The following is a description of a gene set: Genes containing one or more binding sites for (HES2) in their promoter regions (TSS -1000,+100 bp) as identified by GTRD version 20.06 ChIP-seq harmonization. from publication Yevshin I, Sharipov R, Kolmykov S, Kondrakhin Y, Kolpakov F (PMID 30445619) Human Gene Set: HES2_TARGET_GENES studied in species Homo sapiens, and this is the list of marker genes: ADD3, GNAL, SHISAL2B, NACA4P, NRP2, ENSG00000249631, KIFC3, BTF3L4, NEMP1, LINC02214, RPL24, IL1R1, GFPT2, AMBRA1, RNU6-466P, MALAT1, TPRA1, LINC01093, ENSG00000267174, WWTR1, ZC3H12C (zinc finger CCCH-type containing 12C), SLC2A9-AS1, OSBPL1A, SLC7A11, CUEDC1, HISLA, VLDLR-AS1, EPHA2-AS1, MMS19 (NCBI Gene Id 64210), DUSP1, GDI1, PDK1, H2BC21, TNKS1BP1, MIR5194, LINC01719, NRXN2, TUT1, TBC1D16, RN7SKP192, LINC00511, TGFBR2, TM2D2, ABHD16A, C8orf74, MIX23, RNF145, SIAH1, CSF2RA, GPD1L, PDXK, P4HA3, PRCP, CHI3L2, RPL31P43, HMGN1P33 (NCBI Gene Id 100874446), CCL20, MED20, DDIT3, DRAP1, SSR1P2, MED28, CD200R1L-AS1, MTHFD2L, LINC00680, C4orf33, WDPCP, FNDC3A, LDLRAD4, MASP1 (NCBI Gene Id 5648), SAA1, CHP1, ENSG00000226087, ABT1, SLC33A1, FAM107B, XPC-AS1, ASB9, UQCC6, HOXC-AS2, MED28-DT, GPR182, ZSWIM2, PSME2P3, LINC00887 (long intergenic non-protein coding RNA 887), LTBR, RPL39P5, ENSG00000275465, ALG10 (NCBI Gene Id 84920), CXCL8 (NCBI Gene Id 3576), DTWD1, NEDD4, MIR4435-2, LINC01767, MFSD4B, CTR9, PRR13P5, BCL10, ENSG00000267882, FGFR4, ATP9B, SHC4, LINC02843, LINC02454, AIG1, LINC01619, MTCP1, PPP1R15B, TMEM143, VAV3, MIR100HG, TRAF2, EIF4A1, EML2, FKBP9, NECTIN4-AS1, ATG10, PCBP2, SH3TC1, ENSG00000227619, GRIA3 (glutamate ionotropic receptor AMPA type subunit 3), C1QTNF6, BBC3, NDRG1, CAMK2G, EFCAB2, SPRED2, CASK, ABHD12, RPL36AP19, MIR587, MEIS1, GASAL1, HRH1, S100A10, CEP112, KCNK1, MRPS35-DT, IRF2BP1, FGD4, AURKA, SMIM20, SCG5, ANKRD40 (NCBI Gene Id 91369), ENKUR, EDN3, NKILA, DHRS9, HSPA9, FOSL2, CCDC159, BRD4, LINC-PINT, MTARC1 (NCBI Gene Id 64757), RAB5IF, NRAD1, CCNG2, PPARG, SLC38A1, VWA8 (NCBI Gene Id 23078), ISL2, MSL2, LINC02474, APOLD1, ZNHIT1P1, PRDM15, RARB, TSPAN19, BMF, ADGRF4, HRG-AS1, MRPL46, RNA5SP282, TM4SF1-AS1, TPM4, PPP4R1L, IRF2-DT, ZNF641, AOX3P, CLDN7, FPGS, ENSG00000249236, PTPRM, ZNF420, RNU5A-1, ADAM9, CHD2, LINC00706, PLAC1, ZNF547, RNF212, CHD1, SCNN1A, PLD1, IL1RAP, CYP3A43, MDH1, LINC02320, LINC02923, ENSG00000267015, DDIT4, SNORA48, DIO2, EIF4E, RPL35AP17, TRIM29, C2orf76 (NCBI Gene Id 130355), ENAH, EIF5A2, CAPN8, LBP, USP3, NFIA, RPS18P1, TIGD2, GSN, CCND3, BNC2, TPD52L2, NDUFA12, ENSG00000283573 (novel transcript), RAB3D, RBMS3-AS3, GDPD1, LINC02289, AGK, HDAC11-AS1, APBA3, ADRM1, RRBP1, LINC02895, PDK4-AS1, TM4SF1, ANXA2R, PGAM1, PTGFR, DYNLL1P6, LMO7, HNF4A-AS1, WSB2, NGLY1, HM13-AS1, ABCA10 (ATP binding cassette subfamily A member 10), STAT6, STAU2-AS1, POR, RPL4P6, EHF, P4HB, ALG3, COX6CP5, RDX, GALNT9, PLCE1, KIAA2012, ENSG00000225676, LUCAT1, CLIP1, PDK4, OLAH, PNRC1, MARCHF7, C3, SMARCA2, PUDPP1, PTGS2, PNRC1-DT, HCG20, LINC01094, JPX, ZNF280A, IFNL3, SYNCRIP, ZNF619P1, JDP2-AS1, TFRC, ACAP3, KIF17 (kinesin family member 17), LINC02015, MLIP, RCAN1, GAS7, CLDN6, NEAT1, SLC2A4RG, KLF7, NSFL1C, HBP1, MRPS31 (NCBI Gene Id 112759), SLC3A2, CRYBG1, PLOD2, TCF7L2, TFEB, CCDC57, BMP1, FADS1, RNU6-1220P, LINC01134, CHN2, ARHGAP26, EPHB4, RHEB, JPH2, KRT7-AS, CUL3, RPL6, SLC23A1, ZNF286A, ALDH3B1, ENSG00000270571, LCE3D, SNORC, STAT1, E2F2, CELSR1, C1orf21, RNU4-88P, BRF2, TEAD1, GTF3C3, YAP1, PNP, LINC02104, LINC03033, LONRF3, UGT2B10, HNRNPF, AP1G1, PRAME, MIR5696, BNC2-AS1, TMBIM1, DCDC2, CXADR, TDP2, ACOT13, ENSG00000187185, RBBP5 (NCBI Gene Id 5929, RB binding protein 5, histone lysine methyltransferase complex subunit), RPSAP75, TM9SF5P, ADAP1, MANCR, LAMP1, ZBTB7A, GNL3L, PIGO, PNPLA1, ENSG00000227496, SAXO5, INTS5, PDCD6, DENND3, TANK-AS1, CLN6, EP400P1 (EP400 pseudogene 1), CXCL2, LINC02185, FADS3, ITPRIPL2, MMP19, NPIPB8, LINC01730, LINC00160, MSANTD3, SMAD1, SLC44A1, SET, FAM219B, MYOSLID, FERMT2, TLR5, SSBP2, BAZ2B-AS1 (NCBI Gene Id 649559), RFESD (NCBI Gene Id 317671), ATXN10, TPK1, ZNF529 (zinc finger protein 529), FGA, KCNE1, TOMM5, COL7A1, ATXN7L1, MAPK3, PIK3C3, ZNF276, RBM39, EFNA1, PIGU, STAU1, CFAP144P1, KRT8, PARP8, ADHFE1, BUD31, CLASP1, MRO, GPAT3, CLVS1, FMN1, RNA5SP334, CRIPTOP2, LINC01485, HMG20A, COLEC11, PDLIM7, SCUBE2, PIGT (phosphatidylinositol glycan anchor biosynthesis class T), FSIP1, KAT6A, MBP, DNMT3B, LINC01910, DLG5, LRIG3, SLC25A5P7, IGLV3-22, PIK3C2B, CDCA2, H4C10P, SUPT5H, B4GAT1, NFIB, TRPC4AP, CUL2, DEPDC4, MFSD4B-DT, THRA, S100P, PHACTR4, IQGAP2, GZF1, SYBU-AS1, HIVEP2, ETF1, INHBE, SPX, HTR1D, GCLC, ZNF217, CALCOCO2, ITGB1, PSMG3, NFIA-AS1, RBM45, LINC02615, VWC2L, LINC02098, YARS1, KLF13, CDHR17P, STRA6, OSTCP1, DTNA, OR10J6P, LINC02934, S100A12, HES4, UGT2A3P7, SLC7A6, DHRSX, MIR4530, LOLI1, GLTPD2, CHAC1, TFE3, PDE7B-AS1, GUSBP1, RNA5SP146, TMSB4X, RPL7P30, FBXL5, CD59, RPL39P40, KAT2B, TRAPPC5, CDKL3, HDAC11, SGK3, TRPM8, UST-AS2, LINC02888, DPH6, TRAPPC2B, TUBA1C, CALD1, FLJ42393, ENPP3 (ectonucleotide pyrophosphatase/phosphodiesterase 3), C4orf51, RGS20 (regulator of G protein signaling 20), IFNGR1, SMG8, ZNF594, SH2D5, CEACAM19, ACOT7, CYGB, ARFIP1, CNIH3, NFKBIA, SEPTIN2, KIAA0232, ANAPC5, SAMD4B, UBOX5, PRMT5-DT, RAB39B, CIPC, MRPS30-DT, MECP2, LRRFIP2, NAA50P2, RBP4, SRRM3, ANKRD1 (ankyrin repeat domain 1), NMI, ERI1, ZFP36L2, MIB1, ZNF354B, KDM4A, ISG20, LRRC27, ABLIM1, ASCC2, EHMT1 (euchromatic histone lysine methyltransferase 1), POLE4P1, LINC02275, BCO2 (beta-carotene oxygenase 2), KLHDC4, CFLAR-AS1, SMIM14-DT, HOXD11, DDIAS, HK1, LINC00111, AKR1C4, DLGAP1-AS2, LRRC77P, SSTR5-AS1, MNT, SGPP1, GLYATL1, ECHDC3, FAM13A, ABLIM2, ENSG00000239142, RNU6-411P, ENSG00000266313, RUVBL1, ARHGEF19, PER1, CAPS2, NR3C1, MARCHF5, RNU6-1013P, HAL, HAVCR1, NR4A1, TMEM205, FHAD1, MIR4289, ALDH1A2, PNPLA2, LINC01127, SEPTIN9, SMIM36, ZBTB38, ATP5MC2 (NCBI Gene Id 517), E4F1, SCLT1, PRKXP1, ENSG00000199566, SUMO2, AKNA, MIR4440, SLFN12, SLC38A2, TPRG1-AS1, GDF15, PARAL1, SLC2A14, FHL1P1, TET2 (tet methylcytosine dioxygenase 2), CLDN2, RERGL, B4GAT1-DT, TMED2, GNA15-DT, RNF149, NEDD4L, HERPUD2, LRBA (NCBI Gene Id 987), PITPNM2-AS1, ZFAND5, UTY, DPY19L1, TXNRD1 (NCBI Gene Id 7296), HDLBP, DDX27, NAB2, KATNBL1, NCR3LG1, CECR2, ELF1, MRPS23, NBL1, FRG1CP, RNU6-304P, MDP1, ZBTB44, MIR99AHG, SOCS3-DT, MCCC1, RPL7AP4, PLEKHM1 (NCBI Gene Id 9842), ZNF414, SRBD1, CISD1, XPO6, RNU6-117P, CDC7, PVT1, STX1A, NR1H3, NRP1, SPRY4-AS1 (SPRY4 antisense RNA 1), HMGA1P3, SBNO2, RPS6KB1, LINC02331, MTHFD1, GSDMC, EID1, HSPE1-MOB4, SRCIN1, GARS1, PRDM6, ATP11C, RPL26, AADACP1, CIDEC, MRPS5, C4orf46, ORC1, GALNT10, LLPHP3, SH3GL1, FAM227B, ELOVL6, MIOS-DT, EIF2AK3 (eukaryotic translation initiation factor 2 alpha kinase 3), C1orf174, VPS9D1, ZBTB20, ZNF580, ENSG00000229425, HMGCL, MCTP1, KDM3A, TMED10, NCOA7, LINC01151, RN7SL299P, CDK12, KLHL6-AS1, ADCY7, AVL9, ZNF581, HSPE1, SESN2, CCDC192, FAM83A, CAPS (calcyphosine, NCBI Gene Id 828), WDR7, MRPS15, CSTF1 (cleavage stimulation factor subunit 1), NFKBIZ, H4C4, ATP8B4, S100PBP, TMEM91, CS, ZFR, SLTM, MEST, XRCC5, RNA5SP441, RNU1-38P, VMP1, ALDH3A1, LINC02882, NDUFB11, MID1IP1, FBXL18, PUSL1, TBPL1, HSPD1, PMEPA1, TEX41, RN7SL570P, RNVU1-6, UBC, RNY3P12, TRMU, SPPL2A, ALKBH3-AS1, PRPF38A (pre-mRNA processing factor 38A), AJUBA, LINC01433, BEST1, ATAD1, MRPS35, DDC, PDE4D, ERCC4, RASSF9, ITGB3BP, NDUFS4, LINC01775, CLEC4G, USP43, MT2A, ABHD11, PDCD1LG2, FGF14, DENND2B, USP9X, SNORD65C, H2AZ1-DT, MT1F, ETNK2, RDH11, AGPS, ACOX2, DLGAP1, KLF2-DT, ECE2, MYH9, COQ5, LONRF1, RSU1, TRIB1, KLF5, PAM16, TNIP1 (NCBI Gene Id 10318), MAP2K3, ETV6, DHRS12, ARNT, PAXBP1, OAZ1, KNL1, ZNF14, NUF2, PTCH1, PPP1R3B-DT, CALHM5, CCDST, IFT122, IRAK3, IGF2R, THADA, MTMR12, ZNF391, SCMH1, UBXN7, CFAP418, NXN, EPS8, SLC38A4-AS1, FGGY-DT, HGD, MLPH (melanophilin), PDLIM5, PDHA1P1, ENSG00000232995, LINC02198, LURAP1L-AS1, RAB37, EZR-AS1, LINC00598, EVL, TGFBI, RNU5E-6P, PNN, LINC01366, ENO1, SLC9A1, PECR (NCBI Gene Id 55825), IGFLR1, ADAM28, DAAM1, OR10AC1 (NCBI Gene Id 79304), GTF2F2, TCEANC, GREB1, PDCD4-AS1, PLEKHG2, UGT2B28, PRKG2-AS1, ZNF263, MKNK2, ARHGAP24, S100A8, CAV1, ASNSD1, ENSG00000273077, RPSAP65, ZMAT1, FGL1, CUX1, UGT1A7, CASC15, LINC02569, RHCG, DLEU2, DLGAP1-AS1, MISP3, EYS, CLCF1 (NCBI Gene Id 23529), GABRE, TSFM (Ts translation elongation factor, mitochondrial), LINC02410, PTENP1-AS, MBD4, CHEK2, DDB2, TEX12, METTL15 (methyltransferase 15, mitochondrial 12S rRNA N4-cytidine), ALG13 (ALG13 UDP-N-acetylglucosaminyltransferase subunit), MROH1 (NCBI Gene Id 84500), PIWIL2, CYP4B1, RDH12, SNORD118, MIR3611, SHANK2, CFB (NCBI Gene Id 629), KLRK1, GARS1-DT, C1orf226, MIR4799, PER2, OSMR, CCDC88B, LINC00431, PDAP1, TPT1-AS1, ENSG00000212273, RNU4-71P, KRT7, ALOX5AP, FLNB, LINC02026, MBNL1, LINC01275, CCDC9B, ROS1, OGT, TRPM7, LINC00466, RPS7, STAT4, CDK5RAP2, S100A9, NRG1, SKIL, PCID2, SLC22A4, AURKAIP1, ANXA11, CHAF1A, LINC01126, PIGO-AS1, RMDN3, VIM, HSD11B1, MIR3649, EXOC3L4, NME1, TSBP1-AS1 (TSBP1 and BTNL2 antisense RNA 1), ENO3, ABCF2 (ATP binding cassette subfamily F member 2), TNS1 (NCBI Gene Id 7145), RNU1-39P, STAT3, HMGN1P18 (high mobility group nucleosome binding domain 1 pseudogene 18), TXNDC11, HIVEP1, ITPRIP, ABCC3, FUT5, P2RY8 (P2Y receptor family member 8), LINC02831, CYP4A11, LCN2, AOPEP, CCDC171 (NCBI Gene Id 203238), UGT2A2, MAP3K8, ZDHHC3, TGFBR1, CDKL4, EHD1, DAW1, PSMA1, HOOK2, LINC00824, CSAD (cysteine sulfinic acid decarboxylase), RPL34, HECW2-AS1, RNA5SP44, TTI2, OSMR-DT, EFNA5, WASF1, ZNF221, CLK4, ADAR, LINC02209, CSGALNACT1, RUSC2, WIZ, SCN8A, SNX8, SEC62, ISG15, BTBD19, BOD1L1, LINC02352, ABCG1, OR7L1P, CFD, FBN3, JDP2, ZNF200, LINC00112, MIR4276, SMARCD2 (SWI/SNF related, matrix associated, actin dependent regulator of chromatin, subfamily d, member 2), ABCA5, FADS2B, PTP4A1, FTL (NCBI Gene Id 93315), RPL34P18, NIBAN2, GCC2, PRAF2, ERGIC1, SERPINB9P1, DNASE1L3, BMERB1, LMX1B, LINC01909, ENSG00000225656, ANKRD11, IER3-AS1, ENSG00000282849, ITGB1-DT, EZR, SPRY4, NUMB, P4HA2, UGT2A3 (NCBI Gene Id 79799), DMAP1, SYNPO, ENSG00000232876, PSAT1, RACGAP1, SLC1A5, PRMT5, PLEKHH3, UGT2B25P, PTPN12, UPP1, MFSD6, TTC7B, SLC7A5P1, AGTPBP1, BAZ2B, MIR4757, LINC00479, UGT2B7 (NCBI Gene Id 7364), ZNF706, RNF13, SRPX2, TRAV13-2, CCN2, ANXA1, MIR4500HG, RCOR3, MTHFD1L, MED23, CP (NCBI Gene Id 1356, ceruloplasmin), IFNAR1, SMAD7, SUSD1, SLPI, MCL1, MDH2, RPS27AP6, BRWD1, RAB31, SGK1, MUC1, ETFDH, CEBPA, XDH (xanthine dehydrogenase), SNX12, SNX18, TMEM9, LRMDA, GXYLT2, MYO10, CYTH1, RN7SL198P, POLG, ATF3, MIR3926-2, AKR1C3, RNU7-195P, VNN3P, PHLDB2, PARD3, OPN3, LZTFL1, PEAK1, RBM10, MIR4273, ADPRS, RGS5, RNU11, PCBP1, PDGFC, ZFPM2-AS1, DNAH3, DDX10 (DEAD-box helicase 10), HNMT, PRR13, LINC02130, TRIM31, MITF, TGIF1, PDCD6-DT, LINC02532, RN7SL108P, ENSG00000257746 (novel transcript), TEX2, RN7SL836P, C4BPA, RABEP2, UTP3, RHOBTB2, AHCYL1, IRF2, C1S, CDC42SE1, SUMF2, C11orf68, GON4L, BDP1, DRAIC, STK40, MBD6, ADGRG3, ZMIZ1-AS1, DDX60L, INTU, LGALSL, SEPTIN7P14, PTPN20, LINC01186, SLC17A1, ITGA1, TRAPPC3, UBR4, CRYAB, MRPL54, CPSF1, KIF18A, UBE2A, LINC01736, RXRA, ALAS1, PYCR1, NTN4, ATP2C1, TMC1, CEP70, KIAA0319L, SFTPD, PDLIM1 (PDZ and LIM domain 1), BHLHE40, AOX1, MTMR9, NOL11, TBL1X, ENSG00000253270, LINC01549, FBXO38, FOXQ1, TCF4, MGC32805 (NCBI Gene Id 153163), SSTR5, NME1-NME2, PSMF1, MIR5188, RIOK3, PRKCH, DNAJC28, ACTN1, CADM2 (cell adhesion molecule 2), TRIB3, ST20, ALG10B, ZBTB44-DT, SHKBP1, NFIC, SLCO1B7, ZDHHC18, OMG, GALNT18, BOLA1, RNVU1-30, CLGN, MIDEAS, RPL34-DT, TBC1D28, COQ8B, SNHG16, RFX2, ENSG00000266100, NECAP2, DRAM1 (NCBI Gene Id 55332), CDK5RAP1, SMAD6, MRC2, UGT2B11, CCDC83, MIR5091, TNPO1, CSTBP1, SMIM14, FAM9B, CTSC, CHCHD5, TRAV5, UGT2B27P, LINC02989, ITGB5, EXOSC7, RNVU1-26, RPL37AP1, LINC02551, LPIN2, PGC, TIMM13, MYBPC1, SLC7A7, RHOT2, FASTKD5 (FAST kinase domains 5), FLOT1, FAM167A, EEF1AKMT1, GBE1, SLC25A28, LINC02288 (long intergenic non-protein coding RNA 2288), ANKRD13D, CAPN2, NAV2-AS3 (NCBI Gene Id 100874013), ANKEF1, RFFL, NNMT, MIR548H2, KDSR, AREG, SP100, ENSG00000266401, RPAP1, YAF2, ARL14EPL, ARHGAP21, HBS1L, SPATS2L, CDC40, DAGLB, EPCIP-AS1, MPP3, RDH10-AS1, NISCH, LINC02518, CRKL, MTO1, RNF32, CD109, ZC3H12A, ANXA2, PALMD, ANP32B, LINC01960, IGF1R, DNAH11, CSNK1D, CTSD, N4BP2L2, LINC02599, PLCXD1 (phosphatidylinositol specific phospholipase C X domain containing 1), LINC00475, TOR1A, CYB5A, SHTN1, PLIN2, MPP1, KLHL24, MIDN, NFX1, UGT2B24P, RHOBTB3, ADTRP, F7, NHEJ1, RNU6-316P, LINC02428, CEBPB-AS1, DLC1, PLIN1, SLC9B1, OIP5, EBF4, ALPK1, SYNC, C11orf86, CPD, ANXA8, LINC02363, TMEM14C, TXNDC12, CD83P1, ADIPOR2, METAP1, VPS72, ENSG00000243953, B3GNTL1, KMT2A, ZMIZ1, USP54, CCDC18, PRG4, SH2D6, C1RL, HDAC5, ZNF766, DENND10, LINC03108, SETD5, CBX4, PMM1, LTBP1 (NCBI Gene Id 4052), PAWRP1, DBI, ESCO1, SLC45A4, MAFK, LINC02742, TTC7A, DZIP1L, AXL, AATF, FGFR1, HIPK3, MYO18B, FAM186A, RXFP1, GTPBP2, GABRB3, SLC7A8, H4C3, HCAR2, JRK, DLX4, EIF2S3, COTL1, FHL1, RNVU1-27, TNFAIP6, PHF20, ENSG00000238185, SNX27, SERPINB8, ENSG00000214803, ATF6, ABHD4, HOXA5, ZC3H7A, MAP3K20, DCUN1D4, SRI, IL6R, USP45, UBE2B, MCF2L2, RNU6-1310P, BCOR, TNFRSF1A, LINC02542, BDKRB1, CEP85L, ULBP1, DDX47, STC1, RNU4-1, BCL6 (BCL6 transcription repressor), BZW2, SYCN, MRPS30, ARL5AP3, BPHL, POLR2A, TAF1D, NFE2L2, SORBS3, ENSG00000266088, STAT4-AS1, TMEM260, ERICH2-DT, EPHB2 (NCBI Gene Id 50980), RNU6-323P, SUB1, LMX1B-DT, TAGLN2, EDEM1 (ER degradation enhancing alpha-mannosidase like protein 1), RASGRP2, SLC51B, PACERR, PI3, EXD3, PAFAH2, ENSG00000282793, NIBAN1, AGFG2, LINC01914, MCCC2 (NCBI Gene Id 64087), LINC00620, CASP4 (NCBI Gene Id 837), AGK-DT, CD55, ACSS2 (NCBI Gene Id 55902), IDH1-AS1, RPL9P14, MIR193BHG, AFDN, GPRC5A, PTPRG, SMIM2-AS1, FST, IRAG1-AS1, PHYHD1, SYT7, UBB, SLC35D1, TMEM33, AKR1C2, HERPUD2-AS1, COL12A1, HSD17B11, POLG-DT, RN7SL346P, CLCN4, UTRN, TM4SF4, SEL1L3, LINC02243, ARAP3, KLHL4, AKAP6, ENSG00000204684, TMEM40, DDX41, DCBLD1, MIR548H3, TP73-AS3, WASL, ZNF594-DT, TPT1, DCBLD2, MTF2, SRGN, TCF3, CIART, SMPDL3B, ENSG00000207147, SEH1L, GMCL1, MRPL3, SPIDR, MARCHF3, TSEN15, ZBTB4, FOXJ3, SCAT8, GTF2IP12, MAPK15, NIPAL2, PKP4-AS1, CFDP1, SYBU, CMC4, CALM2, LMO4, DUSP6, LIMCH1, PCBP1-AS1, EIF2D, LINC02889 (NCBI Gene Id 101927630), DLST, SQOR, RPH3AL, LINC02952, AQP3, FOSL2-AS1, LINC00963, FOS, POC1A, BMPR1B, RABEPK, CEBPA-DT, SH3BP4, RNU6-800P (NCBI Gene Id 106481433), FAM184A, DEPDC1P2, MIR545, FOXN2, SERPINE1, LINC00240, ME2, SEMA4C, UQCC1, SOCS3, BCR, ELANE, CDRT4, ARID5B, CYP24A1, CTSB, ANK3, SNX16, HMOX1, RCL1, HMGN4, SLC16A1 (NCBI Gene Id 6566), KPNA7, SLC17A5, INAVA, CSTA, IDH1, EPB41, HNRNPU, S100A6, DIXDC1, IRS2, SPIN1